Given this list of marker genes PSMD7, PSMA7, SNCA, SEM1, PSMC1, PSMA6, PSMB7, PSMA2, PSMA4, PSMC2, PSMC5, ADRM1, PSMA3, PSMB4, PSMA5, PSMD14, PSMD13, PSMB1, PSMD3, PSMD4, PSMD6, PSMD12, PSMB6, PSMD2, PSMC6, PSMD8, PSMD9, PSMB5, PSMD11, PSMB2, PSMD1, PSMA8, PSMC4, PSMB3, PSMA1, PSMC3, here is a description of the gene set: Mutation-caused aberrant SNCA to 26S proteasome-mediated protein degradation. Pathway ID: N01030. Pathway type: Variant. Pathway class: nt06463 Parkinson disease. Pathway Definition from KEGG: SNCA* -| 26S Human Gene Set: KEGG_MEDICUS_VARIANT_MUTATION_CAUSED_ABERRANT_SNCA_TO_26S_PROTEASOME_MEDIATED_PROTEIN_DEGRADATION species: Homo sapiens